Given this list of marker genes DNM2, HNRNPDL, MYH7, GNE, KLHL9, LMNA, RYR1 (ryanodine receptor 1), BIN1, BSCL2, MTMR14, MYF6, here is a description of the gene set: Abnormality of the foot musculature species: Homo sapiens Human Gene Set: HP_ABNORMALITY_OF_THE_FOOT_MUSCULATURE An anomaly of the musculature of foot.